Given this list of marker genes GINS2, SLC5A8, GINS3, GINS1, GINS4, here is a description of the gene set: Human Gene Set: GOCC_GINS_COMPLEX A heterotetrameric protein complex that associates with replication origins, where it is required for the initiation of DNA replication, and with replication forks. species: Homo sapiens